Given this list of marker genes Rasgrp2, Guf1, Cyth4, Rasgrp3, Septin14, Rraga, Gtpbp1, Pde6c, Nme2, Ralgps2, Gnat2, Iigp1, Srp54a, Plekhg1, Pde5a, Rab10, Arhgef5, Rab35, Eps8l1, Uprt, Suclg1, Rem1, Hhat, Chm, Rapgef6, Mtg2, Rab43, Mras, Dennd2a, Dnm1l, Hbs1l, Lrrk1, Pde2a, Lamtor3, Irgc, Gnai1, Septin10, Rras, Rabif (NCBI Gene Id 98710), Arl4c, Rasgrp1, Gpn1, Arl4d, Glud1, Arl14, Arf4, Eef1a1, Eif2b2, Nucb2, Dapk1, Eif2b1, Prex2, Slc38a9 (NCBI Gene Id 77071), Mfhas1, Rab39b, Rab8a, Arhgdig, Mief1 (NCBI Gene Id 239555), Arf2, Akap13, Rinl, Eef1b2 (NCBI Gene Id 80613), Rab3ip, Rhog, Rhoa, Gbp10, Pcp2, Rab28, Dock2, Gnai3, Rab32, Gtpbp4, Rap2c, Sergef, Ccdc88a, Ect2, Irgq, Rragc, Rhot1, Vps9d1, Eef1d, Ucp2, Cyth3, Eral1, Arfrp1, Rab3d, Rab34, Cdc42, Mx2, Mocs1, Rabgef1, Rab40b, Rngtt, Tubb3, Rab3il1, Rap2b, Eif2b3, Bcr, Gucy1b1, Gtpbp3, Kndc1, Rab42, Rgs14, Gbp9, Gimd1, Dennd2c, Rap1a, Prkg2, Dock5, Rapgef2, Gbp5, Tuba1c, Arfgef2, Rgl2, Gucy1a1, Rangrf, Rhod, Gnl1, Dis3, Gbp7, Noa1, Rhobtb1, Rin3, Lamtor5, Dock4, Tubd1, Gucy2f, Cngb1, Rp2, Rac3, Eif2s3y, Srprb, Gvin1, Gdi2, Gnai2, Arhgdib, Pde10a, Rabl3, Pck2, Arhgef9, Dock7, Atl3, Cngb3, Septin8, Spata13, Tubb2a, Arhgef38, Dock11, Eras, Dock3 (dedicator of cyto-kinesis 3), Rab29, Arl5b, Rab15, Gucy2g, Arhgef37, Rasl11a, Gem, Dennd2b, Smcr8, Rnf112, Preb, Arhgef11, Rap2a, Gimap8, Rasd1, Fgd3, Iqsec1, Mon1a, Plekhg3, Rcc1, Arhgef28, Arl11, Arhgap35, Septin1, Frmd7, 4930544G11Rik, Prps2, Tuba1b, Rab33a, Prps1, Rab6a, Gapvd1, Pde6g, Rab4a, Iqsec3, Arhgef16, Vav2, Rapgefl1, Gm266, Rpgr, Tagap, Rab9b, Gdpgp1, Rrad, Samhd1, Sh3bp5l, Arhgef17, Gimap5, Tubb4b, Eps8l3, Gnao1, Npr2, Hsp90ab1, Mycbp2, Arfgef1, Cnga3, Irgm1, Dennd5a, Rab25, Tsr1, Lamtor2, Psd2, Gbp4, Gtpbp6, Fgd4, Gpn3, Eftud2, Gna14, Srp54b (signal recognition particle 54B), Obscn, Slc19a1, Rhoq, Rhoc, Gfm1, Ankrd27, Tgm2, Septin5, Rab2a, Psd, Rcc1l, Fgd1, Dock9, Opa1, Nmur2, Rcc2, Rab24, Nme1, Gtpbp10, Gimap7, Sar1a, Rasgrp4, Ccdc88c, Ehd3, Rhov, Rab7, Srpra (signal recognition particle receptor alpha), Rhob, Rabl6, Vav1 (NCBI Gene Id 22324), Eefsec, Hras, Tubb2b, Rasgrf2, Tuba3a, Rapgef5, Itsn2, Septin3, Rap1b, Rasl12, Trim23, Dennd1b, Pip4k2b, Agap2, Rhobtb2 (NCBI Gene Id 78731), Mtg1, Dennd4a, Rab13, Chrm4, Rab33b, Hps1, Septin2, Arhgef18, Gimap6, Arl15, Gnat1, Tubb5, Septin4, Dennd4b, Rasd2, Eps8l2, Eif2b4 (NCBI Gene Id 13667), Eef1a2 (NCBI Gene Id 13628), Sbf1, Adss2, Rapgef4, Arl8b, Cnga2, Arl2, Gpsm1, Rab19, Sar1b, Ric1, Rap1gds1, Arl13b, Efl1, Arl6, Rab20, Tgtp1, Ralgds, Sbf2, Fpgt, Insr, Atl2, Agap3, Gna12, Gnaq, Nkiras1, Rasgef1a (NCBI Gene Id 70727), Rhoh, Tiam2, Rab31, Arf6, Rab2b, Arhgef10, Gna15, Nucb1, Mtif2, Zng1, Net1 (NCBI Gene Id 78563), Gbp2, Cyth2, Rab8b, Dennd3, Fbxo8, Rapgef3, Atl1, Dnm2, Rem2, Arl8a, Rab14, Nkiras2, Rasl2-9, Gna13, Rit2, Fgd2, Rab3gap1, Dennd1a, Gdi1, Sh2d3c, Sos2, Arhgef40, Sh3bp5, Rab12, Rab6b, Ran, Rgl1, Psd3, Lamtor1, Rab5b, Dock8, Arf1, Rab17, Drg1, Rab11a, Cyth1, Lsg1 (large 60S subunit nuclear export GTPase 1), Tgtp2, Arhgef1, Rgl3, Eef2, Gnl3l, Rasef, Rac2, Rhot2, Rigi, Suclg2, Arhgef10l, Cplane2, Rabl2, Cgas, Cnga4, Rab3a, Dennd6a, Wdr41, Eif5b, Rab26, Gnat3, Elmo1, Gimap1, Dnm3, Arhgdia, Rhebl1, H1f4 (H1.4 linker histone, cluster member), Rab4b, Dnm1, Gimap9, Rerg, Als2cl, Gbp2b, Dnmbp, Hps4, C9orf72, Cracr2a, Ciita, Arhgef2 (NCBI Gene Id 99482), Prkg1, Mfn1 (NCBI Gene Id 69518), Nuggc, Dennd4c, Dennd5b, Ccz1, Irgm2, Rragb, Tiam1, Deptor, Kras (NCBI Gene Id 232521), Rasgef1b, Septin7, Nin, Dock6, Gbp3, Rapgef1, Arhgef33 (Rho guanine nucleotide exchange factor 33), Gimap4, Rin2, Rnd1, Diras2, Dock1, Septin9, Hcar2, Rab3gap2, Tbc1d10a, Pck1, Gbp8, Gch1, Ucp1, Rab1b, Rab23, Arl13a, Arl1, Tufm, Agap1, Tubg2, Anxa6, Farp2, Rit1, Gripap1 (NCBI Gene Id 54645), Rab22a, Arfgef3, Gnl3, Psd4, Plekhg6, Pde6h, Arhgef39, Arf3 (NCBI Gene Id 78763), Rab38, Adss1, Gtpbp8, Ehd4, Arhgef19, Mpped2, Nudt2, Rab21 (RAB21, member RAS oncogene family), Dennd11, Tubb6, Gucy2c, Egf, Tuba1a, Rab27b, Ehd1, Arhgef4, Rab11b, Rab3b (NCBI Gene Id 69908), Rtcb, Dennd2d, Srl, Gnas, Rhof, Arl3, Drg2, Sec61b, Ehd2, Gmppb (GDP-mannose pyrophosphorylase B), Eif5, Itsn1, Mfn2, Nras, Urgcp, Ngef, Dnajc27, Mcf2l, Ric8a, Rgp1, Plcg1, Bcar3, Rac1, Eif2b5, Dennd6b, Gspt1, Diras1, Ak3, Fkbp4, Rin1, Rnd3, Eif2s3x, Gna11, Rab36, Rras2, Plce1, Gnl2, Rhou, Pde11a, Rasgrf1, Itgb1bp1, Gspt2, Mx1, Septin6, Sos1, Ola1, Bms1, Thg1l, Gucy2e, Rasl10a, Mmaa, Rasl10b, Ric8b, Rab18, Rab5c, Rala, Arhgef7, Abr, Ift22, Gm12250, Rab40c, Rab1a, Fgd6, Rab44, Hsp90aa1, Plekhg2, Rheb (Ras homolog enriched in brain), Ralgps1, Plcd4, Dennd1c, Rab37, Rnd2, Rab5a, Ranbp10, Ralb, Tuba4a, Prex1, Rab27a (RAB27A, member RAS oncogene family), Vav3, Arhgef15, Tubb4a, Rab9, Gimap3, Arhgef6, Gnal, Gpn2, Tuba8, Rasgef1c, Gfm2, Rab3c, Gbp6, Rab30, Als2, Npr1, Arhgef3, Tubb1, Rab7b (NCBI Gene Id 319567), Sesn2, Arf5, Kalrn, Arl5c, Tube1, Fgd5, Dock10, Rasl11b, Arl10, Srp54c, Tubg1, Cnga1, Sting1, Madd, Acsm1, Rtkn, Ift27, Rhoj, Gnaz (NCBI Gene Id 14687), Dync1li1, Mcf2, Gtpbp2, Sh3bp4, Lamtor4, Lrrk2, Arhgef25, Rragd, Ak4, Chml, Mrgpra1, Arl4a, Arl5a, Ngb, Tubal3, Gpsm2, Dennd10, Arhgef12, Gbf1, Plekhg5, Spag1, Farp1, Septin12, Septin11 (NCBI Gene Id 67780), Rab39, Trio, Iqsec2, Igtp, here is a description of the gene set: studied in species Mus musculus Binding to a guanyl nucleotide, consisting of guanosine esterified with (ortho)phosphate. Mouse Gene Set: GOMF_GUANYL_NUCLEOTIDE_BINDING